Given this list of marker genes RAC1, ABL1, EPHB1, EFNB1, CDK5, ILK, SEMA5B, PDPK1, TRPC1, RYK, WNT4, L1CAM, DPYSL2, NTNG2, FZD3 (NCBI Gene Id 7976), BOC, PLXNA1, ABLIM3, LRRC4C, NCK1, PARD3, WNT5A, PARD6A, DCC, MET, CXCR4, RASA1, BMPR1B, RRAS, SHH, PRKCZ, PTCH1, PRKCA, BMPR2, MAPK1, GNAI1, LRIG2, ROCK1, SEMA7A, ITGB1, CDC42, HRAS, CXCL12, MYL12B, NGEF, NTN3, SEMA3A, RGMA, FES, ROBO2, GDF7, RAF1, EFNA1, UNC5D, GSK3B, SRGAP2, SEMA6C, EPHA2, SLIT2, ROBO1, RHOD, ENAH, NTN4, NRP1, SLIT3, DPYSL5, FYN, SRC (NCBI Gene Id 6714), SLIT1, ARHGEF12, ROBO3, CFL1, here is a description of the gene set: Axon guidance species: Homo sapiens Human Gene Set: WP_AXON_GUIDANCE